The following is a description of a gene set: studied in species Homo sapiens CD4 T follicular helper (Tfh) cells provide the required signals to B cells for germinal center reactions that are necessary for longlived antibody responses. However, it remains unclear whether there are CD4+ memory T cells committed to the Tfh lineage after antigen clearance. Using adoptive transfer of antigen-specific memory CD4+ subpopulations (based on CXCR5 and Ly6c expression)in the LCMV infection model, we found that there are distinct memory CD4+ T cell populations with commitment to the Tfh and Th1 lineages. Our conclusions are based on gene expression profiles, epigenetic studies and phenotypic and functional analysis. The gene expression profiles of virus-specific CD4 T cell subets at effector and memory stages is presented here. Genes up-regulated in CD4 SMARTA memory T cells: Th1 versus Ly6c int CXCR5+. from publication Hale JS, Youngblood B, Latner DR, Mohammed AU, Ye L, Akondy RS, Wu T, Iyer SS, Ahmed R (PMID 23583644) Human Gene Set: GSE43863_TH1_VS_LY6C_INT_CXCR5POS_MEMORY_CD4_TCELL_UP, and this is the list of marker genes: RUVBL2, CST11, ANKRD40, ELAVL1, NFKBIB, IDH3A, SIAH2, SERPINB9, TADA2A, PXN, HMGA1 (high mobility group AT-hook 1), IRGM, PRR3, SLC1A4, EPOP, POLR3D, ECE2, WDR36, BIRC3, NCF1, PLXNC1, TBL1X, ZC3H12A, FUT8, PUS1, STOML2, PUS7L, ZNF207, THOP1, IL6, SLC25A1, WDR4, HPRT1, IL2RA, WDR18, CEP83, CCT6A, MFHAS1, CLIP1, TMEM165, SLC16A1, RRP7A, SLC7A6, RABGGTA, CXCL10, SRSF6, IFRD2, B4GALT5, PDCD1LG2, SLC9A8, SELENOI, SNUPN, POP1, ZZZ3, MYO19, EIF4E, HSP90AA1 (heat shock protein 90 alpha family class A member 1), C5orf22, CHAMP1, PTCD3, KCTD13, ERH, SELENOS, RWDD4, BCL2A1, NUS1, MTOR (NCBI Gene Id 2476), PSMD8, DDX18, TAP1, INTS4, EBI3, PDAP1 (NCBI Gene Id 11333), NAA50, POLDIP2, KSR1, TRMT6, C7orf50, CTPS1, POLR1F, RAP1B, HNF1B, UQCC6, NOC3L, IL10, FOXRED2, RUVBL1, RSL24D1, NAT10, RHBDL3, PSMB2, PLBD2, RBM17, NAA25, GLS, GPS1, PGS1, ZNF639, TSEN2, EIF2B3, DNAJC2, EIF1AY, AGFG1, C15orf48, IL2, TRIM44, URB2, SMYD5, CUL2, GMEB2, CACYBP, SUPV3L1, SLC25A33, WDR5 (NCBI Gene Id 11091), SCARB1, PPAT, TMEM238, AATF, CD40, PUS10, NLE1, CCDC6, CPSF4, PELP1, MRPS2, DDX31, TMEM184B, MAK16, ABCF2 (ATP binding cassette subfamily F member 2), UTP6, ZNF770, ATXN7L3, EIF2S2, PTPMT1, RRP9, LSM12 (LSM12 homolog), GEMIN4, GBP6, BRIX1, TMA16, PHIP, RBM15B, PNPT1, AIMP2, HSPD1, RABL6, HOMER1, GRWD1, HACD3, PPP5C, SRFBP1, CD44, ST6GALNAC4, CPNE3, ADGRL3, NOL11, ID1, CFLAR, HEATR3, UTP14A, MTRR, UMPS, IFNLR1, RIOX1, UTP4, ARFRP1, TSEN54, SPOUT1, ATIC, DDX56, ANKRD28, C9orf72, SOCS3, TRNAU1AP, RCL1, WDR55, CDK5R1, TBL3, BCCIP, ICAM1, MAFG, SF3B3, TMEM39A, LMNB2, IL15RA, CCNB1IP1, NOP9, ARL5A, PECAM1, SRM, PCGF6, MLLT1, ATF3, NFKB2, ETF1, RHEBL1, NSUN2, WIZ, LUC7L, PDF